The following is a description of a gene set: studied in species Homo sapiens from publication Osman I, Bajorin DF, Sun TT, Zhong H, Douglas D, Scattergood J, Zheng R, Han M, Marshall KW, Liew CC (PMID 16740760) Human Gene Set: OSMAN_BLADDER_CANCER_DN PURPOSE: Recent data indicate that cDNA microarray gene expression profile of blood cells can reflect disease states and thus have diagnostic value. We tested the hypothesis that blood cell gene expression can differentiate between bladder cancer and other genitourinary cancers as well as between bladder cancer and healthy controls. EXPERIMENTAL DESIGN: We used Affymetrix U133 Plus 2.0 GeneChip (Affymetrix, Santa Clara, CA) to profile circulating blood total RNA from 35 patients diagnosed with one of three types of genitourinary cancer and compared their cDNA profiles with those of 10 healthy subjects. We then verified the expression levels of selected genes from the Affymetrix results in a larger number of bladder cancer patients (n = 40) and healthy controls (n = 27). RESULTS: Blood gene expression profiles distinguished bladder cancer patients from healthy controls and from testicular and renal cancer patients. Differential expression of a combined set of seven gene transcripts (insulin-like growth factor-binding protein 7, sorting nexin 16, chondroitin sulfate proteoglycan 6, and cathepsin D, chromodomain helicase DNA-binding protein 2, nell-like 2, and tumor necrosis factor receptor superfamily member 7) was able to discriminate bladder cancer from control samples with a sensitivity of 83% (95% confidence interval, 67-93%) and a specificity of 93% (95% confidence interval, 76-99%). CONCLUSION: We have shown that the gene expression profile of circulating blood cells can distinguish bladder cancer from other types of genitourinary cancer and healthy controls and can be used to identify novel blood markers for bladder cancer. Genes down-regulated in blood samples from bladder cancer patients., and this is the list of marker genes: DPF2, SYS1, ZFAS1, SUPT20H, SURF1, FCMR, DIS3L2, MAML2, HIF1AN, CDK12, PIGL, EIF5B, SSU72, ZBED5-AS1, SERTAD2, SNRNP200, ZNF879 (NCBI Gene Id 345462), SMARCC2, HMGN4 (high mobility group nucleosomal binding domain 4), RPS18, TSR3, UACA, SFI1 (SFI1 centrin binding protein), LSM12, H2BC21, SRSF4, ASXL1, NOSIP, GRIPAP1, GATAD2A, PPTC7, SELENOK, TM2D3, SDHAP3, SAMD4B, WDR33, FCRLA, MDM4, ELL, CENATAC, MAN2B1, PML, CARD11, RPL7A, CEP57, TBP, SH2D1A, TMEM243, SEPTIN6, TRAF7, JMJD7-PLA2G4B, RPS17, FAM174A, FMNL1, HCG27, TNKS (tankyrase), RBM33, ITGB2-AS1, RABGAP1L, H4C8, ZSCAN16, FAM221A, STX7, EMD, GFOD3P, ZNF763, MRPS14, AHCYL1, TNFAIP2, SERINC3, EPS15L1, ZFAND2A, DIDO1, BACH2, CHMP3, EFHC1, RPLP0, NINJ1, PDCD4-AS1, EEIG1, MAL, PSMB8-AS1, SCFD2, CTDSP2, EPC1, SEPTIN2, OST4, ZNF133, AKT1, PDE7A, KATNBL1, ZSCAN26, CCAR2, RBM4, VWA8, EDF1, ZNF780B, MED14, RUBCNL, HNRNPC, DMAC1 (distal membrane arm assembly component 1), GART, RPL13, FUNDC1, MARS1, KCMF1, CYRIB, GZMK, POLR2M, RPL36, UST, ARPP19, CD53, ZNF493, FAM220A, PUM1, CUL4A, XPO7, RPS27, RPL28, MTERF4, PRKAR1A (protein kinase cAMP-dependent type I regulatory subunit alpha), CACNA1A, TRAPPC2, PEX16, SKAP1, CELF2, IKZF1, SAFB, MOSMO, NBPF11, ELOVL5, ABCC5, RPL34, DNAJC7, RPL23A, RPL10A, ADPRM, CHST11, GLIPR1 (NCBI Gene Id 11010), SNHG8, FKBP15, CYTIP (cytohesin 1 interacting protein), RPL38, CD27, NOP53, SDE2, MAP3K7CL, LYRM9, ZNF852, PRDX3, MLX, RPSA, PTPRE, TSPAN3, PCBP1-AS1, RALGPS2, ZNF791, ZNF767P, GNG7, UBA52, MRPS6, OFD1, ZNF230, SATB1 (NCBI Gene Id 6304), SMARCC1, RPS3A, RASGRF2, RPL35, NSD3, GOSR1, EBPL, GNAS, NCOA4, TMCC3, MPZL3, TMX2, AOC2, STRBP, SNIP1, RPLP2, SAP30BP, FAM120AOS, TMEM41B, EIF2S3, SIK3, STX17, H1-2, TAGAP, NUDT5, CDC123, SP110, AKT2, SIAH1, ZNF875, NMT2, PHF20, LEPROTL1, ZNF506, ZFP36L1, ABCG1, CELF1, FBL, GSDMD, SNORD104, CHD2, INPP5F, HERC2P9, RPS16, ARHGEF2, TUBD1, SGK1, ARID1A, HNRNPM, RPS15, AGMAT, CMTM2 (NCBI Gene Id 146225), ACTR6, SPATA2, GPBP1, P2RX5, RPS20, RPS24, RPA1, DGKA, NAA10, RPL15, TUG1, ENSG00000238142, ZNF544, RPS5, ZNF677, PRPF3, RPS6, EEF1G, MYO1F, RPL35A, RPS7 (ribosomal protein S7), RHBDD1, ZNF274, SMARCA2, RPGRIP1, RPL24 (NCBI Gene Id 6152), GLMN, CYB5A, ZNF431, SS18L2, BROX, USP7, RPL22, NFATC1, TENT4A, RPS4X (NCBI Gene Id 6191), TGFBR2, RPS11, WDR20, RPL32, IDS, NISCH, AVIL, WIPF2, PITPNC1, VAMP1, RPL4, LINC01410, SERF2, ZNF487, ELL3, MLH3, UBE2B, GAS5, MRPS25, MTCH1, CSTF3, TMEM63A, NFYA, SKI, PABPN1, IREB2, ATL2 (NCBI Gene Id 64225), PDCD4, MARCHF6, RPL13A, PRUNE1, DENND10P1, ERGIC1 (NCBI Gene Id 57222), TTF1, RPL36A (ribosomal protein L36a), NELL2, SNORD60, ST8SIA4, C2orf68, FAU, RPL18A, CHTOP, DDX19A, RNF216, CIAO1, C12orf57, GGA2, C3orf62, FAM30A, GARRE1, FLVCR1, PRMT2, SRSF8, RPS10, PPIF, SIN3A, BUD13, METTL4, MRPS30, RAD50, OCIAD2, SSR4, TSPOAP1-AS1, EPM2AIP1, RPL12, ARHGAP45, KMT5B, TEFM, RPL29P5, RPL29, USP36, PHF1, RPS13, CXCL8, RASGRP2, IRF8, MAP3K13, DEDD2, TOX4, IFT20, QRSL1, CXCL6, DPH5, RPL3, ZC3H6, LBH, BICRAL, DTX4, IP6K2, PHF3, PPP2R5C, OGT, SCAP, OSBPL2, TARDBP, COL18A1, DIS3, TMEM268, ATP8B2, RPS4XP2, MTHFS (NCBI Gene Id 10588), EEF1B2, CSTF2T, EPOR (NCBI Gene Id 2057), ARIH2, PPP2CA, ST3GAL1, ANXA2R-OT1, SPATA2L, ASXL2, SART3, RPS3, DIABLO, COPB2, CLIP1, EPB41, ITPKB, OGA, ENOSF1, MLXIP, TRAF5, RERE, CAMK1D, SART1, ISG20, CYB561D1, ABL2, EIF4A2, ATP8B1-AS1, RPL19, ADNP2, WIPI2, RPL9P7, TRIM38, PM20D2, SRSF6, GABARAPL1, RIGI, ENGASE, LINC01138, HIVEP2, OSER1, MPRIP, PPM1K, MYL12A, MPZL1, RPS21, GATD3, PRPSAP2, STAT3, SNN, PPFIA1, ZNF398, RPS25, RPL14, H2AC6, ST13, RPS6KA5, RHOH, TUBGCP3, SENP1 (SUMO specific peptidase 1), TRIM56, TMC8, SLC7A6, H3-3B, ZNF275, CKLF, IKBIP (IKBKB interacting protein, NCBI Gene Id 387877), PRXL2A, EPB41L4A-AS1, GPR18 (G protein-coupled receptor 18), FCGR2B, RIPK1, RPL37, PPHLN1, CSDE1, HNRNPD-DT (NCBI Gene Id 101928963), SF3A1, ARFGAP2